The following is a description of a gene set: from publication Howe DG, Blake JA, Bradford YM, Bult CJ, Calvi BR, Engel SR, Kadin JA, Kaufman TC, Kishore R, Laulederkind SJF, Lewis SE, Moxon SAT, Richardson JE, Smith C (PMID 30224793) Mouse Gene Set: HALLMARK_INTERFERON_GAMMA_RESPONSE Mouse genes annotated to HALLMARK_INTERFERON_GAMMA_RESPONSE based on orthology mappings provided by the Alliance Genome Consortium studied in species Mus musculus, and this is the list of marker genes: Ifnar2, Lgals3bp, Cxcl11, Sppl2a, Psme2, Cmtr1, Epsti1, Ptpn2, Rbck1, Rigi, Pml, Ifi44, Selp, Ripk2, Gch1, Ifi44l, Sod2, Arl4a, Cdkn1a, Cd274, Irf8, Il6, Dhx58, Tnfaip3, Parp14, Peli1, Marchf1, Bank1, Slamf7, Txnip, Tmt1b, H2-Aa, Ccl7, Ifit2, Parp12 (poly (ADP-ribose) polymerase family, member 12), Fas, Samhd1, Ogfr, Tor1b, Stat4 (signal transducer and activator of transcription 4), Tapbp, Pla2g4a (phospholipase A2, group IVA (cytosolic, calcium-dependent)), Casp4, Il15, Psme1, Cfh, Fpr1, Cmklr1, Irf7, Nfkbia, Casp3, Ifi30, Vcam1, Il10ra, Ccl5, Il18bp, Ptpn1, Ptgs2, Ptpn6, Gzma, Ifi35, Ifih1, Nfkb1, Wars1, Nampt, Cd86, Samd9l, Serping1, H2-DMa, Tap1, Ciita, Vamp8, Mthfd2, Ly6e, Psma3, Trim26, Irf2, Xcl1, Ifitm3, Ncoa3, Zbp1, Sri, Nod1, Psmb8, Mx2, Btg1, Cd69, Stat2, Batf2, Rnf31, Ube2l6, Irf9, Rsad2, Auts2, Adar, Pim1, Nlrc5, Sectm1a, Psmb2, C1s1, Socs3, Lcp2, Hif1a, Herc6, Cxcl9, Sspn, Casp1, Psmb9, Arid5b, Pde4b, Oas2 (2'-5' oligoadenylate synthetase 2), Fcgr1, Bst2, Ddx60, Oasl1, Gbp3, Tdrd7, Stat3, Apol6, Plscr1, Trim21, Lats2, Xaf1, Itgb7, Tnfaip6, Lysmd2, Irf5, Irf1, St8sia4, Mvp, Eif2ak2, Jak2, Rapgef6, Icam1, Lap3, Ifi27, Isoc1, Usp18, Nup93, Cxcl10, Il7, Vamp5, Ifit3, B2m, Bpgm, Pfkp, Myd88, St3gal5, Eif4e3, Cfb, Psmb10, Irf4, Il4ra, Trafd1, Cd40, Trim14, Tnfsf10, Stat1, Oas3, Casp7, Rtp4, Sp110, Gpr18, Znfx1, P2ry14, Tnfaip2, Upp1 (uridine phosphorylase 1), Pnp, Nmi, Trim25, Ripk1, Socs1, Pnpt1, Rnf213, Il2rb, Isg20, Fgl2 (NCBI Gene Id 14190), Cmpk2, Cd38, Casp8, Slc25a28, Cd74, Helz2, Ido1, Il15ra, Ifitm2, Psma2, Isg15